The following is a description of a gene set: Mouse Gene Set: GOBP_IMMUNE_RESPONSE_INHIBITING_SIGNAL_TRANSDUCTION studied in species Mus musculus The cascade of processes by which a signal interacts with a receptor, causing a change in the level or activity of a second messenger or other downstream target, and ultimately leading to inhibition of an immune response., and this is the list of marker genes: Lilrb4b, H2-M3, Sh2d1b1 (SH2 domain containing 1B1), Lyn, Il20rb, Lilrb4a, Clec12b